The following is a description of a gene set: Mouse Gene Set: GOBP_RANDOM_INACTIVATION_OF_X_CHROMOSOME Compensating for the two-fold variation in X-chromosome:autosome ratios between sexes by a global inactivation of all, or most of, the genes on either the paternal or maternal X-chromosome in the XX sex. studied in species Mus musculus, and this is the list of marker genes: Upf3b, Lbr, Hnrnpu, Ftx, Suz12, Jarid2, Xist, Rlim, Pcgf5, Exosc10 (exosome component 10), Hnrnpk, Ncor2, Jpx, Spen, Ctcf, Upf1, Eif1, Upf3a, Hdac3, Pcgf3, Cdyl, Smchd1, Brca1